Given this list of marker genes NEFH, PHGDH, DDX50, DCTPP1, ATIC (NCBI Gene Id 471), ZNF264, FAM217B, CAMK2A, MRPL39, EFHC2, IKBIP, EFHD1, P4HB, PCSK6, SIRT4, UBA7, ABHD14B, CSGALNACT1, B3GNT8, VPS72, DCN (decorin), ST7, TTC3, RUVBL1, SH3PXD2B, IRAK1BP1, AGTRAP, VWA3B, WWOX, P2RX1, RAP2A, SGTA (NCBI Gene Id 6449), TMEM102, CYP46A1, IPO5, RHBDF1, VMAC, CC2D2A, MPZL1, PFKL, ADI1, SUFU, RNF217, SBSPON, SAFB2, UPK1A, VKORC1, UAP1L1, SERINC3 (NCBI Gene Id 10955), CEP70 (centrosomal protein 70), MAPK14, INAFM1, MIR99AHG, FOXRED2, FIRRE, SCRN2, KLF9, ATP6V1B2, MRPL23, CRB3, RAPGEF3, CHAF1B, MARVELD1 (MARVEL domain containing 1), DKKL1, RHOBTB1, ST6GALNAC6, CCDC159, BRSK1, GK, PLAC8, DLG3, FAM83F, MFSD10, RTKN, ANGPT2, CHST13, MCM3, AGO4, NEDD4, SLC16A12 (solute carrier family 16 member 12, NCBI Gene Id 387700), EDEM2, UHRF1, HMGA2, RNF150, PTPRJ, ZNF572, LXN, TMEM116, AK4, CEP126, CHMP4B, NBR1, KCTD14, PRKAR2B, FBXO30, POLR2M (NCBI Gene Id 81488), CADPS, VPS39, COL4A2, VSTM2L, SEC14L5, VLDLR, ZNF296, ALDH1L1, PYM1, CDK4, ARRDC4, SSR3, EIF5A, PCLO, SCHIP1, GPR150 (NCBI Gene Id 387128), GFI1B, COQ2, OPN3, TIMP4, ACBD6, TMEM100, MRPL11, FBXW8, HK2, ABCB10, CA9, NT5C2, KIF13A, AGO1, TRIL, PTPA, CDC5L, PKP2, GP9, FTL, MTARC2, METTL27, SLC43A3, ARHGAP21, IGSF9B, FUT10, NAIF1, RNF149, AFDN, ITPRIPL2, NPR2, SUMO3 (NCBI Gene Id 6612), FLOT1, DENND2A, SEPTIN8, ZNF704, ZEB2, GALNT16, MFSD12 (NCBI Gene Id 60369), THOP1, NABP2, C1orf116, RTN4R, WIPI1, GSDMD, ADGRA3, RHOBTB3, ALDOC, USP27X, MN1, MB21D2, GSK3A, NCKAP1L, SLC39A11, DMWD, TXLNA, OAZ2, RCN1, HDGF (heparin binding growth factor), SERPING1 (NCBI Gene Id 710), KRT26, CHST12, DOCK6 (NCBI Gene Id 57572), FAM167A, SLC22A3, CKAP4, LONRF2, PNPLA2, TREML2, ABHD11, HEPH, TCIM, MRPL2, NSD2 (nuclear receptor binding SET domain protein 2), B9D1, CNPY3, IL1R1, ACOX1, CPLX2, HTRA2, CCDC9, ATP13A2, HAGHL, TTPA, XAB2, FPGS, RAB27B, here is a description of the gene set: Among the multiple mechanisms that control the intensity and duration of macrophage activation, the development of a state of refractoriness to a second stimulation in cells treated with LPS has long been recognized. Release of inhibitory cytokines and alterations in intracellular signaling pathways may be involved in the development of LPS tolerance. Although a number of molecules have been implicated, a detailed picture of the molecular changes in LPS tolerance is still missing. We have used a genome-wide gene expression analysis approach to (i) define which fraction of LPS target genes are subject to tolerance induction and (ii) identify genes that are expressed at high levels in tolerant macrophages. Our data show that in LPS tolerant macrophages the vast majority of LPS-induced gene expression is abrogated. The extent of tolerance induction varies for individual genes, and a small subset appears to be excepted. Compared to other negative control mechanisms of macrophages, e.g. IL-10-induced deactivation, LPS-tolerance inhibits a much wider range of transcriptional targets. Some previously described negative regulators of TLR-signaling (e.g. IRAK-M) were confirmed as expressed at higher levels in LPS-tolerant macrophages. In addition, we discuss other potential players in LPS tolerance identified in this group of genes. Genes up-regulated in naïve macrophages: untreated versus LPS. studied in species Homo sapiens from publication Mages J, Dietrich H, Lang R (PMID 18086374) Human Gene Set: GSE8621_UNSTIM_VS_LPS_STIM_MACROPHAGE_UP